Given this list of marker genes FZD2, FZD1, DLG1, MMP25, ITGB8, FOXE1, GABRB3, ITGB6, SOX11, here is a description of the gene set: species: Homo sapiens Human Gene Set: GOBP_HARD_PALATE_DEVELOPMENT The biological process whose specific outcome is the progression of the hard palate from an initial condition to its mature state. This process begins with the formation of the structure and ends with the mature structure, whatever form that may be including its natural destruction. The hard palate is the anterior portion of the palate consisting of bone and mucous membranes.